Given this list of marker genes Gfral, Gfra4, Gfra2, Gfra1, Gfra3, here is a description of the gene set: Combining with glial cell line-derived neurotrophic factor and transmitting the signal from one side of the membrane to the other to initiate a change in cell activity. species: Mus musculus Mouse Gene Set: GOMF_GLIAL_CELL_DERIVED_NEUROTROPHIC_FACTOR_RECEPTOR_ACTIVITY